Given this list of marker genes SPI1, EIF3A, ST6GAL1, HSPA2, EIF4G1, AMMECR1, RAD21, HBS1L, R3HDM1, CCNH, MRPL24, RPL37, SNHG3, WSB1, NEAT1, FBRS, SENP6, FBXO22, RPL19, PSMD13, ZGPAT, GTF2H5, H4C3, NSD2, RCBTB1, GALNT1, NOP16, EYA3, WASHC4, TAF9 (TATA-box binding protein associated factor 9), PACC1, TAOK3, TFDP2, YWHAH, RNF123, IRF3, OGDH, GGPS1, CLUAP1, SLC25A13, ZNF576, SPIN1, PAK2, KIF2A, GNAQ, CALM1, EMC2, GSE1, KPNA1, UBE2G2, RTCA, ANP32A (NCBI Gene Id 8125), GUCA2B, TRPV2 (NCBI Gene Id 51393), RNF167, ITCH, GON4L, CTBP2, SCRIB, FNBP1, IL10RB, CYP2D6, BPHL, SCAF11, TOB2, DCAKD, ARHGAP26, TNFSF13, MRPS15, TUT7, ACTA1, APEX2, UBE2K, ZMAT3, FAM135A, BUD23, RAB6B, H2BC9, AP2B1, RBMX, OAS3, ZNF7, H2BC5, NCK1, SH3BGRL3, SCAMP2, DHX40, HIF3A, FEM1B, UBE3A, DCBLD2, RECQL4, EIF2B2, RAB8A, SLC4A7, AKAP6, GADD45B, ITGB2, HSPG2, PTRH2, HDAC4, JPT2, HSD17B7, GATAD2A, NPM1, SINHCAF, APAF1, TIPRL, KNOP1, EN2, NACA, BRD4, KLHL28, TNPO2, SART1, PFN1, PRKCSH, TLE5, GNAI2, OSBP, TIMP2, PPP2R5E, TRIM38, TRPS1, SLC5A6 (solute carrier family 5 member 6), H2AC18, SMG7, KMT5B, MPG, TGFB1, TULP2, GPHN, ASRGL1, NR2F1, RALBP1, L3MBTL1, LGALS9, TNFAIP1, NOC2L, DPP3, ZMYND8, OSBP2, BMP2K, RAD23A, ATXN2L, SIGMAR1, ATRX, GTF2F1, SGCE, EID1, SCAND1, BANF1, NECAP1, STX5, SOCS1, NENF, KLF12, UBE4A, H2BC6, WBP4, HGSNAT, TIMM10B, SF3A2, RCAN3, RBBP5, CLASP1, C1orf54, FNBP4, ARL2, RSRC1, RHOB, SENP3, FAR2, LSP1, CD69, COPA, SMAD2, PFDN2, CTSO, NGF, PDE6D, PEAK1, MYCBP2, RPL35, KPNB1, RBM28, PSMA4, RPL18, IKZF1, SHMT2, LPP, APOBR, GJA5, ENTREP3, H4C8, F2RL1, TLN1, PTPN18, H2BC10, ADCK2, here is a description of the gene set: Human Gene Set: GSE29618_PRE_VS_DAY7_POST_TIV_FLU_VACCINE_PDC_DN Genes down-regulated in comparison of plasmacytoid dendritic cells (pDC) from TIV influenza vaccinee pre-vaccination versus those at day 7 post-vaccination. studied in species Homo sapiens Systems vaccinology has emerged as an interdisciplinary field that combines systems wide measurements and network and predictive modeling applied to vaccinology. Here we used the systems vaccinology approach to study the molecular mechanisms underlying th from publication Nakaya HI, Wrammert J, Lee EK, Racioppi L, Marie-Kunze S, Haining WN, Means AR, Kasturi SP, Khan N, Li GM, McCausland M, Kanchan V, Kokko KE, Li S, Elbein R, Mehta AK, Aderem A, Subbarao K, Ahmed R, Pulendran B (PMID 21743478)